The following is a description of a gene set: Subpopulations of human fetal thymocyte and circulating naïve T cells were obtained through FACS sorting, including CD3-CD4+CD8- intrathymic T progenitor cells (ITTP), CD3intCD4+CD8+ \double positive\ thymocytes (DP), CD3highCD4+CD8- \single positive\ thymocytes (SP4), CD3+CD4+CD8-CD45RA+CD62L+ naive T cells from cord blood (CB4+), and CD3+CD4+CD8-CD45RA+CD62L+ naive T cells from adult blood (AB4+). from publication Lee MS, Hanspers K, Barker CS, Korn AP, McCune JM (PMID 15210650) Human Gene Set: GSE1460_INTRATHYMIC_T_PROGENITOR_VS_NAIVE_CD4_TCELL_CORD_BLOOD_DN Genes down-regulated in comparison of intrathymic T progenitor cells (ITTP) versus naive CD4 T cells from cord blood. species: Homo sapiens, and this is the list of marker genes: ZNHIT3, ZNF467, IL11RA, RPS16 (NCBI Gene Id 6217), GAL, ADORA2B, PACSIN3, SORL1, ARHGEF6, TGFBR2, SYNE1, PLAC8, NPY4R, GRHL2, MORC2, PPP2R2B, KCNJ14, GRB10, GJB1, SERPINI2, RGL1 (NCBI Gene Id 23179), DDX27, PCOLCE, ADRB3, S100A6, CSF1R, EBAG9, ST6GAL1, PRMT2, CRYGC, EEIG1, MYL12B, GZMA, BARX1, MTNAP1, GALNT11, HIVEP2, HTR2B (NCBI Gene Id 3357), MEGF6, ATP10A, SLC8A2, EPHB3, IPPK, UFL1 (UFM1 specific ligase 1), PDCD4, SIRPA (NCBI Gene Id 96784), MYEF2, SMYD2, DYNLT1, MSRA, RAPGEF6, WWC1, FXYD3, RAB22A, COL18A1, IGLJ3, MVK, SCGB2A2, FAU, HCP5, MARK1 (microtubule affinity regulating kinase 1), ALDH3A2, GDF2, SERPINF2, PIP5K1B, HTR7, PDE4B, CTDSP2, KRT15 (keratin 15), ZNF460, TAF1, TMEM243, DUSP22, UNC119, SLC7A7, ACOT11, RNF17, ZNF510, MAN1C1, RHOF (NCBI Gene Id 54509), ZNF155, CASP10, ADCYAP1, TRIB2, CPTP, IFITM1, MAB21L4, ZNF835, GP5, PPARD, DNMT3L, PLXNA1, TNFRSF1B, MADCAM1, PPP2R5B, STIM1, IL32, MALT1, LLGL2, HOXC6, OPRPN, ZNF571, RBM19, LHFPL6, PLEKHB1, MAPK13, ADCY2, ABCG4, LMOD1, HEG1, DIP2C, SELENBP1, KCNH2, TNIP2, SERPINC1, CKAP4, ATP9B, CAMK4 (calcium/calmodulin dependent protein kinase IV), OR7E19P, DNAJB4, TPK1, AFAP1, RSAD1 (NCBI Gene Id 55316), STX16, CIB1, ATP12A, RYBP, TNFSF10, PLEK2, CEBPD, TXK, CELSR3, CSF2, DGCR2, SLC17A7, ACADSB, IL24, FRAT1, S1PR1, AGRN, CYLD, NCR2, RACK1, TGFB3, BCL10, ALPG, CAPN3, PLEKHA1, RBM47, LY9, CDC42SE1, CD177, TESMIN, FRY, CRHBP, GPRASP1, DNAJC22, ZNF516, ATP11A, DLX5, UBE2D4, ALX3 (ALX homeobox 3), LRRN3, CABIN1, PSORS1C2, ABHD8, IGHV5-78, ADAM15, BCO1, SCNN1B, MXRA8, BNIP3, GALNT8 (NCBI Gene Id 51803), MAST4, PGLYRP4, ABI3BP, NPPA, SLC6A7, NME3, KRT2, ZCCHC2, CBY1, CAPN2, PASK, TRAF3IP3, IER2, TSPAN14, TRDV2, MAPK3, MS4A3, KCNC3, MINDY1, PHF20, AHCYL2, MRPS14, MSX2, TDRD3, ZFP36L1, KRT23